Given this list of marker genes Ldhc, Ldhd, Ldhal6b, Ldhb, Ldha, here is a description of the gene set: Mouse Gene Set: GOMF_LACTATE_DEHYDROGENASE_ACTIVITY studied in species Mus musculus Catalysis of the reaction: lactate + NAD+ = H+ + NADH + pyruvate.